Given this list of marker genes ACER1, KRT76, EXT1, FA2H, SMAD4, GATA6, TFAP2C, ASH1L, ZDHHC21, RBPJ, WNT10A, here is a description of the gene set: The process whose specific outcome is the progression of the sebaceous gland over time, from its formation to the mature structure. studied in species Homo sapiens Human Gene Set: GOBP_SEBACEOUS_GLAND_DEVELOPMENT